The following is a description of a gene set: studied in species Homo sapiens Any process that modulates the frequency, rate or extent of myoblast proliferation. Human Gene Set: GOBP_REGULATION_OF_MYOBLAST_PROLIFERATION, and this is the list of marker genes: MIR133B (microRNA 133b), MIR204, ATF2, SOX15, MEIS2, MALAT1, FGF7, KCNA5, KLHL41, IGF1, MEGF10, PPARD (NCBI Gene Id 5467), CTNNB1, MYOD1, PAX7, FGFBP1, MIR199A1, GATA6, MIR499A, MIR1-1, PAXBP1, SIX1, MSTN, MIR134 (microRNA 134), MIR133A1, MIR10A, ZNF609